Given this list of marker genes ALG3, TSHZ2, SALL2, METTL2A, SPRING1, ADCK5, BTRC (beta-transducin repeat containing E3 ubiquitin protein ligase), DUSP10, here is a description of the gene set: Human Gene Set: CAO_BLOOD_FLUZONE_AGE_05_14YO_30DY_UP Genes up-regulated in blood 30d vs 0d in children (0.5-14y) after exposure to Fluzone, time point 30D. Comment: ~80% of cohort were white, ~50/50 Female:male BACKGROUND: Live attenuated influenza vaccine (LAIV) and trivalent inactivated influenza vaccine (TIV) are effective for prevention of influenza virus infection in children, but the mechanisms associated with protection are not well defined. METHODS: We analyzed the differences in B-cell responses and transcriptional profiles in children aged 6 months to 14 years immunized with these 2 vaccines. RESULTS: LAIV elicited a significant increase in naive, memory, and transitional B cells on day 30 after vaccination, whereas TIV elicited an increased number of plasmablasts on day 7. Antibody titers against the 3 vaccine strains (H1N1, H3N2, and B) were significantly higher in the TIV group and correlated with number of antibody-secreting cells. Both vaccines induced overexpression of interferon (IFN)-signaling genes but with different kinetics. TIV induced expression of IFN genes on day 1 after vaccination in all age groups, and LAIV induced expression of IFN genes on day 7 after vaccination but only in children < 5 years old. IFN-related genes overexpressed in both vaccinated groups correlated with H3N2 antibody titers. CONCLUSIONS: These results suggest that LAIV and TIV induced significantly different B-cell responses in vaccinated children. Early induction of IFN appears to be important for development of antibody responses. from publication Cao RG, Suarez NM, Obermoser G, Lopez SM, Flano E, Mertz SE, Albrecht RA, García-Sastre A, Mejias A, Xu H, Qin H, Blankenship D, Palucka K, Pascual V, Ramilo O (PMID 24495909) species: Homo sapiens